The following is a description of a gene set: Human Gene Set: REACTOME_DIGESTION_OF_DIETARY_LIPID Digestion of dietary lipid species: Homo sapiens, and this is the list of marker genes: PNLIP, CEL, PNLIPRP1, PNLIPRP3, CLPS, PNLIPRP2, LIPF